The following is a description of a gene set: Genes negatively differentially expressed in cell type: pDC (plasmacytoid dendritic cell) upon treatment with cytokine: IL-15 in mouse lymph nodes in vivo. Cytokines mediate cell-cell communication in the immune system and represent important therapeutic targets. A myriad of studies have highlighted their central role in immune function, yet we lack a global view of the cellular responses of each immune cell type to each cytokine. To address this gap, the authors created the Immune Dictionary, a compendium of single-cell transcriptomic profiles of more than 17 immune cell types in response to each of 86 cytokines (>1,400 cytokine-cell type combinations) in mouse lymph nodes in vivo. A cytokine-centric view of the dictionary revealed that most cytokines induce highly cell-type-specific responses. For example, the inflammatory cytokine interleukin-1β induces distinct gene programmes in almost every cell type. A cell-type-centric view of the dictionary identified more than 66 cytokine-driven cellular polarization states across immune cell types, including previously uncharacterized states such as an interleukin-18-induced polyfunctional natural killer cell state. Mouse Gene Set: CUI_PDC_IL15_RESPONSE_DN studied in species Mus musculus from publication Cui A, Huang T, Li S, Ma A, Pérez JL, Sander C, Keskin DB, Wu CJ, Fraenkel E, Hacohen N (PMID 38057668), and this is the list of marker genes: Pdcd4, Bmyc, Ubb, Cox7a2l, Eef1a1, Pold4, Naca, Nop53, Ripor2, Bri3, Snx29, Sox4, Pabpc1 (NCBI Gene Id 18458), Eef2, Rreb1, Cat, Nsa2, Atosa, Slc23a2, Spns3, Pnisr, Syk (NCBI Gene Id 20963), Klhl24, Peli2, Klf2, Zfp36l2, B3gnt8, Ramp1, Luc7l2, Tsc22d1, Cmah, Ypel3, Uba52, Eid1, Maf1, Btg2, Rnaset2b, Cdip1, Mxd4, Sirpa, Eif4ebp2, Foxp1, Il16